Given this list of marker genes Pdgfb, Il6ra, Egr1, Serpinb7, Itgb3, Pdgfd, Cflar, C3ar1, here is a description of the gene set: Mouse Gene Set: GOBP_POSITIVE_REGULATION_OF_GLOMERULAR_MESANGIAL_CELL_PROLIFERATION studied in species Mus musculus Any process that increases the frequency, rate or extent of glomerular mesangial cell proliferation.